The following is a description of a gene set: studied in species Homo sapiens Hypoplasia of the femoral head Human Gene Set: HP_HYPOPLASIA_OF_THE_FEMORAL_HEAD Underdevelopment of the femoral head., and this is the list of marker genes: TRAF3IP1, POP1, IFNGR1, IDUA (NCBI Gene Id 3425), SLC26A2